Given this list of marker genes Ms4a4c, Actb, H2-D1, Ifi30, Crip1, Lcp1, B2m, Alox5ap, Sh3bgrl3, Taldo1, Arpc1b, Napsa, Ctsc, Ctsz (cathepsin Z), Ctss (NCBI Gene Id 13040), Ccl4, Fxyd5, Psmb8, Tagln2, Cyba, Fau, Ucp2, H2-DMa, H2-K1, Tmsb4x, Psap, Lgmn, Laptm5, Rac2, Arpc3, Picalm, Lgals3, Cd52, H2az1, Rgs1, Cst3, Rps11, Ccl3, Sub1, Atox1, Pim1, Mpeg1, H2-DMb1, Cd209a, Rps29, Mcl1, Plbd1 (NCBI Gene Id 66857), Lilrb4b (leukocyte immunoglobulin-like receptor, subfamily B, member 4B), Fcer1g, Bcl2a1b, Cotl1, Bcl2a1d, Rpl18a (ribosomal protein L18A), Lmnb1, Bhlhe40 (NCBI Gene Id 20893), Gm2a, Tyrobp, Ms4a6c, Wfdc17, Clec7a (C-type lectin domain family 7, member a), Gpr132 (G protein-coupled receptor 132), Tspo, Cytip, H2-Aa, Nr4a3, Cfl1, Arpc5, Zfp36, Arhgdib, Rgs2, Cxcl16, Cdkn1a, Il1r2, Spi1, Fth1, Actg1 (NCBI Gene Id 230535), Ifitm3, Ccl6, Lsp1, Unc93b1, Syngr2, Il1b, Cd83, H2-Ab1, Coro1a, Cd53 (CD53 antigen), Calm1, Plek, Cd74, Arpc2, Psme1, H2-Eb1, Rilpl2, Srgn (NCBI Gene Id 19073), here is a description of the gene set: Mouse Gene Set: ZHANG_UTERUS_C9_DENDRITIC_CELL Table S2: Representative genes of each cell cluster from publication Zhang L, Long W, Xu W, Chen X, Zhao X, Wu B (PMID 35669188) species: Mus musculus